Given this list of marker genes Gm11917, Gm11919, Mif-ps11, Gm11907, Gm25378, Gm11909, Epha7 (Eph receptor A7), Gm11910, here is a description of the gene set: Mouse Gene Set: chr4A4 studied in species Mus musculus